The following is a description of a gene set: from publication Qualls JE, Neale G, Smith AM, Koo MS, DeFreitas AA, Zhang H, Kaplan G, Watowich SS, Murray PJ (PMID 20716764) Human Gene Set: GSE22935_WT_VS_MYD88_KO_MACROPHAGE_48H_MBOVIS_BCG_STIM_DN species: Homo sapiens Genes down-regulated in macrophages 48h after M. bovis BCG infection: wildtype versus MYD88 knockout. Nitric oxide (NO) produced by macrophages (MØs) is toxic to both host tissues and invading pathogens and its regulation is therefore essential to suppress host cytotoxicity. MØ arginase 1 (Arg1) inhibits NO production by competing with NO synthases for arginine, the common substrate of NO synthases and arginases. Two signal transduction pathways control Arg1 expression in MØs. First, a MyD88-dependent pathway induces Arg1 in intracellular infections, while a second Stat6-dependent pathway is required for Arg1 expression in alternativelyactivated MØs. We found that mycobacteria-infected MØs produce soluble factors that induce Arg1 in an autocrine-paracrine manner via Stat3. We identify these factors as IL-6, IL-10 and GCSF. We further establish that Arg1 expression is controlled by the MyD88-dependent production of IL-6, IL-10 and G-CSF rather than cell intrinsic MyD88 signaling to Arg1. Our data reveal the MyD88-dependent pathway of Arg1induction following BCG infection requires Stat3 activation and may result in the development of an immunosuppressive niche in granulomas due to the induced Arg1 production in surrounding uninfected MØs, and this is the list of marker genes: DENND10, PKD2, SKIL, TNIP2, AGPAT4, LHFPL2, ADAM19, FXYD2, NSG1, HLA-DRB1, BRK1, ADCY7, GALNT7, CCR1, CD84, SEC24D, SYNE3, PITPNA (phosphatidylinositol transfer protein alpha), ARPC2, NCF2, TMED9, GPX1, IL1R1, ALDH18A1, TRRAP, WIPF1, RAB35, HPSE, SH3KBP1 (NCBI Gene Id 94010), FSTL1 (NCBI Gene Id 65385), GPR34, ALG11, HASPIN, CREB3L3, CD9, MALT1, PARP8, AEBP1, ITPRIP, RIPK2, CYSLTR1, HLA-DMB, BIN3, HCST, TMEM68, TSPAN31, CAMK1D, NOC2L, GALNT9, DSEL, PNP, CD244, SPRED1, KIFC1, STAP2, CORO1C, ITGB2, SLC66A3, GCFC2, WLS, CDK6, COL3A1, RHOC, EIF1AY, ALOX5AP, ANKRD49, TM9SF1, PLEKHF1, VIM, PICALM, FRRS1, CD86, SLC25A30, PRDM1, SRI, C1QA, MED13L, VWA5A, TMEM164, CMTM6, LIX1L, PSD3, DENND11, SLC7A11, TES, MDFIC, ANTXR1, SHTN1, ATP7A, MMP13, CERS6, CRIP1, SOAT1 (sterol O-acyltransferase 1), GNG10, PLK3 (NCBI Gene Id 1263), LHFPL5, ATP6V1H, CYBB (cytochrome b-245 beta chain), ATRNL1, ZNHIT1, SOCS3, ADGRE5, CCSAP, SLC30A7 (solute carrier family 30 member 7), RMC1, AVPI1, LUZP1, F2RL1, NHP2, SLC6A20, MED7, WDR82, ANKIB1, SH3BGRL3, P2RY6, RNF169, STX11, ACTR3, DAP, MOB1A, KLF6, MAPK3, ANXA2, PPP4C, TADA1, IL34, CSK, CD48, HM13, SYT1, SEC61A1, CHIC2, RGS3, ZDHHC20, ACER3, TNFAIP3, MYO1G, MAPK1IP1L, TRAM1, KCNN4, SPG21, CYP51A1, EPCAM, BACH1 (NCBI Gene Id 571), RIN3, PLPP6, ZNF217, ATP6AP2, IL1RL2, TGFBR1, NPC2, PLP2 (NCBI Gene Id 5355), DCSTAMP, PPRC1, ZCCHC9, SDCBP, NFKBIA, LRRC8C, ELOVL1, TRIO, F11R, NCF1, LGALS1, ITGAV, CTHRC1, TMEM123, RUNX3, HLA-DQA1, TMEM128, NEURL1B, CMPK1, PLIN2, DPT, BTK, REEP4, TXNDC17 (NCBI Gene Id 84817), MARCHF1 (membrane associated ring-CH-type finger 1), UBASH3B, PTGER2, TBC1D9, GPR137B, STARD4, RAB8B, HMOX1, LAT2, BAIAP2 (BAR/IMD domain containing adaptor protein 2), LITAF, RAI14, PLAT (NCBI Gene Id 5327), RAB31, TMEM165, ANXA1, KDELR1, MANF, MVD, ABTB3, CLIC1, PIP4P1, TNFAIP8, PIP4K2A